The following is a description of a gene set: studied in species Mus musculus Transport of small molecules Mouse Gene Set: REACTOME_TRANSPORT_OF_SMALL_MOLECULES, and this is the list of marker genes: Slc35c1, Ryr1, Apoc1 (NCBI Gene Id 11812), Slc9a4, Slc36a2, Gng12, Slc17a1, Abca3, Atp2a2, Slc9a5, Abcd3, Atp8b2 (NCBI Gene Id 54667), Psmc2, Slc17a7, Lipg, Slc5a1, Slc8a2, Hmox1, Clca2, Asph, Atp13a5 (NCBI Gene Id 268878), Slc1a3, Atp2c1, Mcoln3, Slc26a6 (NCBI Gene Id 171429), Psmd1, Slc26a1, Mlkl, Slc11a2, Trpm3, Prkaca, Csn1s1, Slc4a2, Asic1, Ap2a2, Derl2, Atp11b, Abcc4, Slc6a3, Ctns, P4hb, Slc38a4, Slc24a5, Slc32a1, Apoe, Abcf1, Nr1h2, Lrrc8a, Slc12a6, Ank, Abcb5, Trpc4, Ubc, Lpl, Add3 (adducin 3), Tpcn1, Lrrc8e, Slc35a2, Aqp1, Slc35b3 (NCBI Gene Id 66728), Slc22a7, Psmd6, Angptl8, Ano7, Psmb7, Atp6v1g3, Psma4, Atp2b4, Scnn1b, Cyb5r4, Slc22a18, Uba52, Trf, Lmf2 (lipase maturation factor 2), Pcsk6, Slc22a6, Ano2, Hdlbp, Trpv1, Slc5a2, Slc50a1, Slc2a3, Slc41a2, Atp6v1e1, Magt1, Atp10d, Slc46a1, Psma2, Psmc1, Dmtn, Cltc, Lipa, Slc17a6, Lrrc8b, Abca12, Slc30a8, Asic2, Slc40a1, Sgk2, Slc12a5, Apoa2, Apoa5, Slc6a7, Slc1a2, Fbxl5, Wwp1, Slc6a11, Psmc5, Pip, Slc22a3, Slc17a8 (solute carrier family 17 (sodium-dependent inorganic phosphate cotransporter), member 8), Scarb1, Flvcr1, Atp4b, Slc9a3, Slc22a2, Slc2a13, Slc45a3, Ano6, Car4, Abcb9, Lrrc8d, Slc44a1, Slc38a1, Clta, Slc13a3, Slc28a1 (solute carrier family 28 (sodium-coupled nucleoside transporter), member 1), Rps27a, Psmc3, Psmb4, Slc5a12, Gng3, Slc9a1, Slc2a7, Slc6a2, Apoa1, Slc7a7, Aqp3, Eif2s2, Clcn2, Slc6a19, Slc2a9, Slc44a3, Slco2a1, Clcn1, Psmd12, Tfr2, Micu2, Ripk1, Slc22a12, Gng4, Derl1, Slc17a3, Slc34a2, Gnb3, Car2, Slc18a2, Slc1a4, Camk2g, Camk2d (calcium/calmodulin-dependent protein kinase II, delta), Abca9, Slc6a1, Slc38a3, Atp1b2, Slc39a3, Slc25a1, Psmb2, Aco1, Erlin2, Slc9a8, Esyt1, Angptl3, Cyb5r1, Micu1, Psmd2, Slc2a2, Slc6a9, Camk2a, Atp8b1, Slc2a8, Psma3, Atp12a, Slc7a3, Cybrd1, Ttyh3 (NCBI Gene Id 78339), Abcc5, Prkar1a, Atp11c, Slc30a1, Slc36a4, Slc3a1, Atp6v0b, Steap4, Cptp (ceramide-1-phosphate transfer protein), Slc25a29, Raf1, Slc14a2, Slc5a9, Trpv3, Aqp2, Ano5, Apod, Ireb2, Slc36a1, Slc2a12, Slc39a8, Lrrc8c, Calm2, Atp6v1g2 (ATPase, H+ transporting, lysosomal V1 subunit G2), Atp6v1b2, Slc6a6, Nipa2, Slc39a1 (NCBI Gene Id 386471), Atp6v1h, Atp8b3, Ftl2-ps, Trpc1, Trpc3, Slc25a18, Avpr2, Cul1, Trpc6, Slc4a4, Ano4, Psma7, Slc4a9, Atp2b1, Slco4c1, Trpm7, Soat2, Abcg5, Slc1a7, Slc29a1, Slc12a3, Angptl4, Slc29a4, Rhbg, Lcn12, Slc5a11, Csn3 (NCBI Gene Id 12994), Slc44a4, Abcb6, Stom, Lcn9, Atp6v1c2, Trpv6, Slc1a5, Slc25a4, Atp1a4, Ano10, Slc4a1, Nipal3 (NCBI Gene Id 74552), Hbb-bt, Slc9b2, Atp13a4, Slco1c1, Lcn2, Slc39a2, Trpv2, Slc22a8, Clca4b, Avp, Arf1, Ostm1, Slc16a2 (solute carrier family 16 (monocarboxylic acid transporters), member 2), Slco1b2 (solute carrier organic anion transporter family, member 1b2), Ubb, Cyb5rl, Slc26a3, Slc9a6, Slc5a5, Abcc3, Ryr3, Slc5a7, Apoa4, Mcoln1, Phb1, Trpm2, Casq2, Slc4a7, Ano3, Abcc2, Hbb-bs, Slc13a4, Parl, Slc38a2, Mcu, Atp6v0c, Abcd1, Atp6v0d1, Aqp9, Cygb, Cyb5r2 (NCBI Gene Id 320635), Fxyd2, Trdn, Phb2, Slc35d2, Atp6v0e2, Gngt2, Soat1, Abcd2, Gng11, Slc22a1, Asic3, Slc43a1, Slc35b4, Abcc1, Atp6v1d, Calm3, Esyt3, Trpc5, Nipa1, Slc10a6, Slc3a2 (solute carrier family 3 (activators of dibasic and neutral amino acid transport), member 2), Npc1, Slc24a4, Slc13a1, Slc16a10, Mfsd4b4, Psma5, Fxyd1, Slc25a11, Trpv4, Fth1, Kcnj11, Alb, Atp1a1, Abca4, Vldlr, Maip1, Slc34a1, Ces3a, Atp6v0a2, Slc26a7, Zdhhc8, Slc8a1, Ap2m1 (NCBI Gene Id 11773), Slc20a2, Afg3l2, Cp, Slc27a6, Slc31a1, Gnb5 (guanine nucleotide binding protein (G protein), beta 5), Nedd8, Ldlr, Slc16a8, Erlec1, Ap2b1, Apoc4, Slc6a15, Azgp1, Trpm4, Trpm8, Nipal4, Vcp, Psmd13, Ces3b (carboxylesterase 3B), Slc15a1 (solute carrier family 15 (oligopeptide transporter), member 1), Gnb4, Esyt2, Slc9a2, Rab11fip2, Spg7, Slc26a4, Nedd4l, Slc2a10, Slc5a3, Ano1, Tcirg1 (NCBI Gene Id 27060), Cftr, Tusc3 (tumor suppressor candidate 3), Atp7b, Slc34a3, Atp7a (ATPase, copper transporting, alpha polypeptide), Atp2a3, Slco4a1, Heph, Mttp, Atp2a1, Asic4, Slc41a1, Stoml3, Atp1b1 (NCBI Gene Id 11931), Plekha8, Yme1l1, Atp13a1, Slc7a5 (solute carrier family 7 (cationic amino acid transporter, y+ system), member 5), Abca1, Abcc10, Tpcn2, Abca6, Slc7a1, Bsg, Pex19, Apobr, Slc28a3, Atp6v1e2, Atp13a2 (ATPase type 13A2), Best1, Slc4a3, Atp2b3, Trpm5 (transient receptor potential cation channel, subfamily M, member 5), Slc22a17, Abca2, Slc17a5, Slc6a5, Abcg4, Pltp, Atp10b, Atp6v0a4, Psmb1, Atp6v0a1, Slc9a7, Cand1, Slc13a2, Slc12a7 (NCBI Gene Id 52539), Gng7, Fxyd4, Slc66a1, Clcn6, Slc4a8, Arl2bp, Slc39a7, Add1, Atp6v1f (NCBI Gene Id 66144), Mip, Clcnkb, Gng10, Atp9a, Rnf185, Slc1a1, Asic5, Psmb5, Slc7a10, Slc24a3, Slc38a5, Slc13a5, Slc22a16, Lmf1, Apoc2l, Pex3, Camk2b, Trpc7, Nr1h3, Slc15a4, Calm1, Atp6v1g1, Hfe, Mcoln2, Prkar1b, Slc44a2, Fxyd7, Slc6a20a, Psma6, Gpihbp1, Nalcn, Hba-a1, Slc33a1, Clcn4, Psmb3, Atp6v0d2, Slc35a1, Os9, Slc8b1, Psmd3, Ripk3, Slc22a15, Slc39a14, Smdt1, Atp6ap1, Abcc9, Slc16a1, Lipc, Ahcyl2, Ano8, Slc9b1, Slc27a1, Slc12a4, Sgk3 (NCBI Gene Id 72422), Abcb7, Atp1a3, Gnb2, Scnn1g, Atp6v1c1, Fxyd6, Apob (NCBI Gene Id 238055), Slc22a4, Slc24a2, Sar1b, Slc12a2, Slc25a5, Nceh1, Psmd14, Slc25a22, Pcsk5, Slc18a1, Micu3, Sel1l, Car1, Slc11a1, Unc79, Psmc4, Sri, Slc8a3, Arl2, Aqp8 (aquaporin 8), Trpv5, Slc27a4, Best2, Slc35a3, Atp9b, Slc15a3, Atp4a, Scnn1a, Slc39a4, Ldlrap1, Atp2c2, Best3, Slc25a26, Nipal1, Mcub, Slc1a6, Abca7, Sgk1, Mrs2, Slc26a11, Slc35b2, Clcnka, Fgf21, Rhag, Psmd11, Ngb, Psmd7, Slc2a6, Abcb8, Slc6a18, Slc14a1, Unc80, Casq1, Uba52rt, Npc2, Rab11a, Slc35d1, Nipal2, Erlin1, Furin, Abcg1, Ap2a1, Aqp4, Stoml2, Apoc2, Atp1a2, Slc26a9, Slc6a14, Slc30a5, Rnf5, Fkbp1b, A2m (NCBI Gene Id 232345), Add2, Clcn5, Slc5a4a, Pmpcb, Atp2b2, Gltp, Slc43a2, Slco1a4, Abca8b, Ap2s1, Ttyh2, Trpm6 (NCBI Gene Id 225997), Slc12a1, Trpa1, Rhcg, Slc16a7, Bsnd, Clca1, Atp6v1b1, Atp11a, Atp8a1, Slc7a11, Clcn7, Atp8b4, Slc5a8, Psmb6, Emb, Psmc6, Abca5, Skp1, Pln, Slco3a1, Cln3, Eif2s1, Myo5b, Slc2a4, Slc7a8, Ftmt (ferritin mitochondrial), Ttyh1, Bmp1, Gng5, Trpc4ap, Gnas, Adrm1, Ano9, Abcg8, Lcat, Slc28a2, Atp6v0e, Atp6v1a, Pdzd11, Slc5a10, Pmpca, Slc47a1, Slc25a10, Aqp12, Slco2b1, Gm28035, Slc7a9, Abcc6, Slc24a1, Slc5a6, Aqp11, Prkacb, Slc29a3, Abcb4, Slc6a12, Slc26a2 (solute carrier family 26 (sulfate transporter), member 2), Gngt1, Slc6a13, Derl3, Abcb1a (ATP-binding cassette, sub-family B member 1A), Slc7a6, Slc9a9, Atp8a2, Tfrc, Aqp7, Atp1b3, Steap3, Mb, Slc39a6, Slc16a3, Psmd8, Pcsk9, Ryr2, Slc30a10, Hmox2, Eif2s3x, Slc4a10, Gnb1, Slc22a5, Trpm1, Aqp5, Slc20a1, Slc29a2, Fxyd3, Mylip, Psma1, Atp10a, Gng2, Gng13, Slc4a5, Slc44a5, Slc2a1, Gng8